Given this list of marker genes ENSG00000289011, CACNB1, MLLT6, GGNBP2, RNU6-840P, CCL4, ENSG00000275173, RNU6-1192P, MIR378J, SRCIN1, SPMAP1, RNU6-233P, TBC1D3F, CCL2, TMEM132E-DT, CCL11, CCL18, CCL8, LHX1-DT, NEUROD2, GPR179, HMGB1P24, LRRC37A9P (NCBI Gene Id 100533790), ARHGAP23, ENSG00000297644, RPL19, SOCS7, CCL14, GRB7, YWHAEP7, ENSG00000289485, ENSG00000263571, PLXDC1, PPP1R1B, RPL23, CCL4L2, MIR4728, LHX1, PIP4K2B, MIR4734, CWC25, ENSG00000277182, C17orf50, SLFN12, UNC45B, TBC1D3, TBC1D3L, STAC2, PSMB3, CCL3-AS1, PNMT, ERBB2, CDK12, TBC1D3D, AP2B1, DDX52, LYZL6, TBC1D3K, TBC1D3B, HNF1B, LINC02079, PIGW, RN7SL301P, MIEN1, LASP1, ZNF830, TBC1D3H, STARD3, TBC1D3E, ZNHIT3 (NCBI Gene Id 9326), TAF5LP1, CCL16, CCL7, CISD3, SLFN14, LINC01989, RNA5SP526, LASP1NB, PEX12, SLFN11, TLK2P1, MIR4727, MIR2909, CCL1, RNU6-489P, MMP28, MRM1, RNA5SP439, HEATR9, CCL5, RAD51D, ENSG00000270240, TCAP, ARL5C, SNORA21B, AATF, ENSG00000302878, DHRS11, CCL3, MYO19, PGAP3, PCGF2, TOMM20P2, GAS2L2, MIR6779, MRPL45 (mitochondrial ribosomal protein L45), MIR4726, NPEPPSP1, NLE1, SNORD7, RDM1, SLFN13, CCT6B, UFM1P2, TADA2A (transcriptional adaptor 2A), ASIC2, TAF15, TBC1D3I, AA06, CCL15, RDM1P5, RNU6-866P, RNA5SP440, ENSG00000276170, SNHG30, SLFN5, CCL23, SNORA21, DUSP14, SYNRG, ENSG00000306162, RFFL, CCL13, E2F3P1, TBC1D3C, MED1, RASL10B, ACACA, CCL15-CCL14, SLFN12L, LIG3, EPOP, TBC1D3JP, LRRC37A11P, SPICP2, TMEM132E, C17orf78, FBXO47, TBC1D3G, FBXL20, SLC35G3, ENSG00000301862, FNDC8, CCL3L3, RNA5SP438 (RNA, 5S ribosomal pseudogene 438), here is a description of the gene set: species: Homo sapiens Human Gene Set: chr17q12